Given this list of marker genes Slc3a2, Kmo, Slc36a4, Ido2, Ido1, Kynu, Aadat, here is a description of the gene set: Reactome Pathway: Tryptophan catabolism part of: Metabolism of amino acids and derivatives species: Mus musculus electronically inferred by orthology from the curated human pathway This event has been computationally inferred from an event that has been demonstrated in another species.<p>The inference is based on the homology mapping from PANTHER. Briefly, reactions for which all involved PhysicalEntities (in input, output and catalyst) have a mapped orthologue/paralogue (for complexes at least 75% of components must have a mapping) are inferred to the other species.